Given this list of marker genes AREG, KDM3A, DACH1, ITM2B, SLC20A1, KRT12, FCRLA, ZC3H12C, CASP3, GPAT4, ADCY3, PALD1, TUBB2A, SPEG, GDF9, RNF141, MAPKAPK2, SEMA3C, PDRG1, LIG3, IFRD1, DMRT1, VAC14, HSPA1A, SPINK4, SLC7A8, MSH3, HERPUD1, BAG2 (BAG cochaperone 2), IL1A, AQP1, IKZF2, TMEM266, MCM5, CRADD, HOXA4, GTPBP2 (GTP binding protein 2), CLOCK, TOP1, YJU2B, SLC7A7, SCAMP1, TBPL1, GNA15, STAB1, RHOB, EZH2, ZNF638, NTF3, HPGD, NFKBIZ, P3H3, GLRX, SCOC, BCL2A1, RPS6KB1, PSENEN, CASQ2, PCBP1, MMP24, ST3GAL2 (NCBI Gene Id 729518), MYL3, SNX3, SRP68, HYOU1, ZNF326, SGK1, DDIT3, FAM110A, ELOA, C15orf39, IPO4, TNF, MAPK8, PHLDA1, SIM1, VPS37B, G0S2, MPHOSPH10, KMT2E, TSR1, CDK14, NR4A1, ZNF276, KLF10, HSP90AB1, ZNHIT1, GABRR1, TLCD4, LHCGR, STMN3, POLG, ACRV1, AGXT, SMNDC1, NFE2L2, FKBPL, ENSG00000286190, CHD4, SLC1A2, DERL2, IRF5, MADCAM1, ZIC4, SLC25A25, GPC4, ANAPC15, TXNIP, METTL17, TAGLN (transgelin), CXCL2, PTPRF, MYBBP1A, RLIM, MERTK, UNCX, ISLR, STX1B, CACNA1G, DCAF1, FOS, TUBA1C, CPS1, VEGFA, CNTFR, CSF2, PCDHA10, CAMK2B, JUNB, KRT16, GAB2, PRPH2, GPR65, FTL, IMPACT, WNT3, GEM, SIX1, GLYR1, CD2, SOX10, NKIRAS2, DUSP6, ZFP57, PHKB, CUL2, DARS1, FRK, PDXK, FGF10, CCNG2, MYORG, PLIN4, FEN1, CDC20, CSF1, CITED2, PSMC4, CXCL3, SPOCK1, MRPS24, SPICE1, BCL6, PLAUR, LRP2, DUSP1, TRIM13, LMO4 (NCBI Gene Id 8543), MRM3, FHL1, EHHADH, PRKD2, SOX1, ALKBH5, RNASE1, MRPS12, WNT2B, IGFBPL1, SCN1A, PEBP1, BUB1, ACO1, ANAPC16, MDM2, CDKN2AIPNL, PODXL, FLCN, SERPINA12, PHKG1, MBTD1, FBN1, ACP5, TNIP1, KRR1, SH3D19, PDGFB, REM1, RSRP1, POLR3A, SH3BP2, here is a description of the gene set: Genes up-regulated in CD4 T helper cells (52h): Th0 versus TGFB1 and IL6. Human Gene Set: GSE43955_TH0_VS_TGFB_IL6_TH17_ACT_CD4_TCELL_52H_UP Despite their enormous importance, the molecular circuits that control the differentiation of Th17 cells remain largely unknown. Recent studies have reconstructed regulatory networks in mammalian cells, but have focused on short-term responses and relied on perturbation approaches that cannot be applied to primary T cells. Here, we develop a systematic strategy – combining transcriptional profiling at high temporal resolution, novel computational algorithms, and innovative nanowire-based tools for performing gene perturbations in primary T cells – to derive and experimentally validate a temporal model of the dynamic regulatory network that controls Th17 differentiation. The network is arranged into two self-reinforcing and mutually antagonistic modules that either suppress or promote Th17 differentiation. The two modules contain 12 novel regulators with no previous implication in Th17 differentiation, which may be essential to maintain the appropriate balance of Th17 and other CD4+ T cell subsets. Overall, our study identifies and validates 39 regulatory factors that are embedded within a comprehensive temporal network and identifies novel drug targets and organizational principles for the differentiation of Th17 cells. species: Homo sapiens from publication Yosef N, Shalek AK, Gaublomme JT, Jin H, Lee Y, Awasthi A, Wu C, Karwacz K, Xiao S, Jorgolli M, Gennert D, Satija R, Shakya A, Lu DY, Trombetta JJ, Pillai MR, Ratcliffe PJ, Coleman ML, Bix M, Tantin D, Park H, Kuchroo VK, Regev A (PMID 23467089)